Given this list of marker genes GPRC5A, BRINP2, AOX1, LINC01258, GAS1, VTN, MYRF, RARRES1, TFPI2, CLDN15, BDKRB1, COL11A1 (NCBI Gene Id 317718), PLA2G2A, ALOX15, UPK3B, ATP7B, BNC1, ADGRD1, SGSM3-AS1, SPHKAP, EXTL1, CPA4, TGM1, LINC02232, PTPRQ, INMT, PPP2R2C, CLDN1, CFB, FGF1, GSDME, MSLN, MUC16 (mucin 16, cell surface associated), GNGT1, SLAIN1, LRP8-DT, GRIN3A (NCBI Gene Id 138370), RPL21P21, SI, LINC02643, HAS1, RSPO1, ALDH1A2, SILC1, PLA2G10, KLK5, SCEL, LINC00922, TMEM151A, CELF2-AS2, KLF5, CCBE1 (NCBI Gene Id 147372), LINC01606, LRRN4, C19orf33, RAET1E, SMTNL2, GFPT2, CRB2, WNT2B, WT1, CLIC5, ITPKC, MT1A, LRP2 (NCBI Gene Id 4036), LINC02360, COL8A1, CHAC1, FAM13A-AS1, NEK5, SERTAD4-AS1, KLK11, NFATC2, OTOGL, RPRM, TNNT1 (troponin T1, slow skeletal type), KLK10, ROR1-AS1, SERTM1, here is a description of the gene set: from publication Cao J, O'Day DR, Pliner HA, Kingsley PD, Deng M, Daza RM, Zager MA, Aldinger KA, Blecher-Gonen R, Zhang F, Spielmann M, Palis J, Doherty D, Steemers FJ, Glass IA, Trapnell C, Shendure J (PMID 33184181) The gene expression program underlying the specification of human cell types is of fundamental interest. The study authors generated human cell atlases of gene expression and chromatin accessibility in fetal tissues. For gene expression, the study authors applied three-level combinatorial indexing to >110 samples representing 15 organs, ultimately profiling ~4 million single cells. The study authors leveraged the literature and other atlases to identify and annotate hundreds of cell types and subtypes, both within and across tissues. Our analyses focused on organ-specific specializations of broadly distributed cell types (such as blood, endothelial, and epithelial), sites of fetal erythropoiesis (which notably included the adrenal gland), and integration with mouse developmental atlases (such as conserved specification of blood cells). These data represent a rich resource for the exploration of in vivo human gene expression in diverse tissues and cell types. Human Gene Set: DESCARTES_FETAL_PANCREAS_MESOTHELIAL_CELLS studied in species Homo sapiens Marker genes curated from the annotated cluster as represented in the Descartes Human Gene Expression During Development database.